The following is a description of a gene set: Any process that stops, prevents, or reduces the frequency, rate or extent of small GTPase mediated signal transduction. species: Mus musculus Mouse Gene Set: GOBP_NEGATIVE_REGULATION_OF_SMALL_GTPASE_MEDIATED_SIGNAL_TRANSDUCTION, and this is the list of marker genes: Ppp2cb, Abl2, Bcl6, Mfn2, Rasal1, Stambp, Arhgap35, Adra1a, Arhgap42, Itga3, Gmip, Heg1, Lztr1, Arhgap45, Cul3 (cullin 3), Timp2, Syngap1, Adra1b, Mapkap1, Ccdc125, Sh3bp1, Scai, Cyrib, Flcn, Arhgap12, Slit2, Met, Dgkz, Spry2, Nf1, Arhgap25, Myoc, Ripor2, Dlc1, Arhgap24, Wnk1, Rasal3, Cgnl1, Fbp1, Rasip1, Stmn3, Rabgef1, Tgfb2, Rasa4, Dab2ip, Spry4, Rasa2, Nup62 (NCBI Gene Id 52394), Tnk1, Kctd10, Arhgap44, Arhgap17, Spry1, Kank1, Ripor1, Ephb2, Stmn1, Trim67, Itgb1, Rapgef1, Cd2ap, Rasa3, Kctd13, Arhgap22, Tns3, Git1, Arhgap29, Tnfaip1